The following is a description of a gene set: Mouse Gene Set: MIR_7024_5P species: Mus musculus from publication Chen Y, Wang X (PMID 31504780) Genes predicted to be targets of miRBase v22 microRNA mmu_miR_7024_5p in miRDB v6.0 with MirTarget v4 prediction scores > 80 (high confidence targets)., and this is the list of marker genes: Xkr6, Mymk, Tbc1d7, Hnrnpab, Usp50, Tdrd3, Hdac1, Fam163b, Igf1, Zdhhc15, Zfp637, Atg7, Fgfr4, Camk1d, Slc22a27, Zfp36l2, Chrm1, Snapin, Sncb, Nectin1, Sox6, Tomm34, Mex3a (NCBI Gene Id 72640), Klf13, Tmem8b, Pde1b, Lhfpl1, Klf12, Ppard, Map3k13, Ube2f, Eif2ak3, Ppp1r9b, Pou3f2, Zfp646, Alx4, Bloc1s5, Prlr, Slc18a1 (NCBI Gene Id 352946), Cyp2u1, Csnk1g1, Shisa9, Gng11, Wfdc6b, Mink1, Lhx6, Smco1, Tnfsf8, Popdc3, Dlk1 (NCBI Gene Id 13386), Krtdap, Lrrc58, Gimap5, Pknox2, Smap1, Tbc1d30, Kmt2a, Kcnc3, Lama3, Zfp710 (NCBI Gene Id 74497), Gzmb, Srgap3, Lyz3, Col1a1, Alkbh1, Nek8, Cd2ap, Tmem63a, Cpd, Ccdc68, Ube3a, Pef1, Wfdc6a, Igf2bp1, Mrpl50, Grk5, Cbx6, Clns1a, Atf7 (NCBI Gene Id 77354), Frmd7, Scg2, Cdhr1, Cacna1e, Cartpt, Zfp606, Fam117b, Nos1, Glmp, Pld6, Rps6kc1 (ribosomal protein S6 kinase polypeptide 1), Abca13, Nt5dc1 (5'-nucleotidase domain containing 1, NCBI Gene Id 319638), Actb, Dpp6, Stum, Abca5, Dhdh, Slc38a7, Irx5, Isl1, Nfix, Afmid, Slc6a17, Ssx2ip, Bin1, Zfhx2, Nfasc, Tbc1d23, Lrrc28